The following is a description of a gene set: Any process that activates or increases the frequency, rate or extent of feeding behavior. studied in species Mus musculus Mouse Gene Set: GOBP_POSITIVE_REGULATION_OF_FEEDING_BEHAVIOR, and this is the list of marker genes: Ghsr, Sgip1, Drd1, Npy, Agrp, Nr4a3, Mc1r, Ghrl, Rxfp4, Oprk1, Cfap20, Insl5, Mtor